The following is a description of a gene set: IKK complex recruitment mediated by RIP1 studied in species Homo sapiens Human Gene Set: REACTOME_IKK_COMPLEX_RECRUITMENT_MEDIATED_BY_RIP1, and this is the list of marker genes: TRAF6, RIPK1, UBE2D3, UBB (NCBI Gene Id 91253), IKBKB, LY96, BIRC2, TICAM1, UBE2D1, TLR4, UBC, UBE2N, UBA52, IKBKG, RPS27A, UBE2V1, SARM1 (NCBI Gene Id 23098, sterile alpha and TIR motif containing 1), CHUK, CD14, RIPK3, BIRC3 (baculoviral IAP repeat containing 3), TICAM2, UBE2D2